Given this list of marker genes Slc9b2, Siglec15, Tnfsf11, Gpr68 (NCBI Gene Id 238377), Ltf, Fbxw7, Ninj1, Fbn1 (NCBI Gene Id 99016), Tyrobp (NCBI Gene Id 22177), Tjp2, Notch2, Cldn18, here is a description of the gene set: Any process that modulates the frequency, rate or extent of osteoclast development. Mouse Gene Set: GOBP_REGULATION_OF_OSTEOCLAST_DEVELOPMENT species: Mus musculus